Given this list of marker genes SHH, WNT3A, FGF20, SFRP1, FERD3L, TIAM1, FOXA1, SFRP2, DKK1, GSK3B, ID2, here is a description of the gene set: studied in species Homo sapiens Any process that modulates the frequency, rate or extent of dopaminergic neuron differentiation. Human Gene Set: GOBP_REGULATION_OF_DOPAMINERGIC_NEURON_DIFFERENTIATION